Given this list of marker genes CCNA1, CDC25C, TICRR, CDC25B, OBI1, PPP2CB, FOXM1, CDK2, MIS18BP1, CCNH, CCNB2, XPO1, LCMT1 (NCBI Gene Id 51628), PPP2R2A, CDK7, HJURP, PPP2R1A, PPP2CA, PPP2R1B, CDK1, PPME1, MNAT1, CCNB1, CDC25A, BORA, WEE1, CCNA2, PLK1, FZR1, PKMYT1, PPP2R3B, SGO1, here is a description of the gene set: Cell cycle progression is regulated by activation of cyclin-dependent protein kinases at G1/S, S/G2, and G2/M transitions. Completion of DNA replication at the S/G2 transition allows activation of CDK1 and PLK1. Recent evidence implies that the activation of Cyclin A:CDK1 (CCNA:CDK1) complexes promotes the activation of AURKA, which promotes the activation of PLK1, which then promotes the activation of Cyclin B:CDK1 (CCNB:CDK1) complexes. Inhibitory PKMYT1 and WEE1 kinases prevent premature activation of CDK1 complexes. The CDC25 family phosphatases (CDC25A, CDC25B, and CDC25C), activated at G2/M transition, remove the inhibitory phosphorylations and, together with the activating phosphorylation mediated by the CAK complex, enable the full activation of CDK1 complexes. CCNA:CDK1 and CCNB:CDK1 complexes phosphorylate a large number of proteins involved in mitosis (M phase), including lamins and other proteins involved in nuclear envelope breakdown, proteins involved in mitotic spindle formation, and proteins involved in disassembly of the Golgi apparatus. While CDK1 complexes may exhibit a high level of redundancy in vitro, their substrate specificity in vivo is partially determined by their subcellular localization, with CCNA:CDK1 complexes being mainly nuclear, the CCNB1:CDK1 complex being mainly cytosolic, and the CCNB2:CDK1 complex localizing mainly to the Golgi membrane. In addition, while CCNA2, CCNB1, and CCNB2 are ubiquitously expressed, CCNA1 is predominantly expressed in the testes and plays an important role in meiosis, but it is also implicated in mitosis in specific cell types, such as hematopoietic stem cells. CCNB3 functions exclusively in meiosis. Reactome Pathway: Cyclin A/B1/B2 associated events during G2/M transition studied in species Homo sapiens part of: G2/M Transition